The following is a description of a gene set: Any process that modulates the frequency, rate or extent of centriole elongation. Mouse Gene Set: GOBP_REGULATION_OF_CENTRIOLE_ELONGATION species: Mus musculus, and this is the list of marker genes: Cep295, Vps4b, Ppp1r35, Chmp2a, Cep120, Cenpj, Ccdc15, Poc5, Poc1b